The following is a description of a gene set: Genes commonly up-regulated in both non-tumorous and tumorous liver tissues of PARK2 knockout mice. species: Mus musculus The parkin was first identified as a gene implicated in autosomal recessive juvenile Parkinsonism. Deregulation of the parkin gene, however, has been observed in various human cancers, suggesting that the parkin gene may be important in tumorigenesis. To gain insight into the physiologic role of parkin, we generated parkin-/- mice lacking exon 3 of the parkin gene. We demonstrated here that parkin-/- mice had enhanced hepatocyte proliferation and developed macroscopic hepatic tumors with the characteristics of hepatocellular carcinoma. Microarray analyses revealed that parkin deficiency caused the alteration of gene expression profiles in the liver. Among them, endogenous follistatin is commonly upregulated in both nontumorous and tumorous liver tissues of parkin-deficient mice. Parkin deficiency resulted in suppression of caspase activation and rendered hepatocytes resistant to apoptosis in a follistatin-dependent manner. These results suggested that parkin deficiency caused enhanced hepatocyte proliferation and resistance to apoptosis, resulting in hepatic tumor development, partially through the upregulation of endogenous follistatin. The finding that parkin-deficient mice are susceptible to hepatocarcinogenesis provided the first evidence showing that parkin is indeed a tumor suppressor gene. from publication Fujiwara M, Marusawa H, Wang HQ, Iwai A, Ikeuchi K, Imai Y, Kataoka A, Nukina N, Takahashi R, Chiba T (PMID 18574468) Mouse Gene Set: FUJIWARA_PARK2_HEPATOCYTE_PROLIFERATION_UP, and this is the list of marker genes: Hspa1a, Asns, Nat8, Fst, Hsd3b5, Sult1e1, Cxcl1, Apoa4, Tfb2m, Wfdc15b, Apcs, Abhd1, Cyp4a12a